Given this list of marker genes Map2k7, Nlrx1, Mapk14, Ubb, Tirap (toll-interleukin 1 receptor (TIR) domain-containing adaptor protein), Mapk9, Map3k8, Rps27a, Ecsit, Nfkb2, Nkiras1, Mapk11, Ube2v1, Ppp2r1b, Ppp2r5d (NCBI Gene Id 21770, protein phosphatase 2, regulatory subunit B', delta), Jun, Mapk8, Nlrc5, Map2k6, Ikbkb, Mapk3 (mitogen-activated protein kinase 3), Hmgb1, Tab1, Cul1, Dusp6, Rps6ka5, Mapk7, Rela, Tab3, Nfkbia, Dusp7, S100b, Nfkb1, Map2k3, Nfkbib, Tab2, Peli2, Ube2n, Map2k4, Irak1, Lrrc14, Fos, Tifa, Vrk3, Casp8, Ager, here is a description of the gene set: This event has been computationally inferred from an event that has been demonstrated in another species.<p>The inference is based on the homology mapping from PANTHER. Briefly, reactions for which all involved PhysicalEntities (in input, output and catalyst) have a mapped orthologue/paralogue (for complexes at least 75% of components must have a mapping) are inferred to the other species. electronically inferred by orthology from the curated human pathway Reactome Pathway: Toll Like Receptor TLR1:TLR2 Cascade species: Mus musculus part of: Toll Like Receptor 2 (TLR2) Cascade